Given this list of marker genes Cox6a1, Mt2, Snx21 (sorting nexin family member 21), Gfra2, Fabp5, Ngfr, Tgfbi, Slc25a4, Cltb, Hnrnpab, Havcr2, Sult1a1, Ddr1, Tmem256, Cd244a, Runx1, Casp6, Snap23, Ms4a6d, Socs3, Rnh1, Gpatch11, Tspo, Ugcg, Gcnt1, Ifitm2 (NCBI Gene Id 80876), Olfm1, Adpgk, Mrpl52, Edem1, Cyp4f16, Fcgrt, Dhx9, Slc39a1, Flot1, Gpr146, Cyrib, Ndufv2, Cdk2ap2, Wfdc17, Ap1s2, Snrpa, Lyn, Skap2, Ocstamp, Fkbp5, Mt1, Smdt1, Gpr183, Pirb (NCBI Gene Id 18733), Gapdh, Clec4n, Pmvk, Septin3, Cpne2, Gpr171, Kif1a, Rab3il1, Wdr1, Gcnt2, Cox7a2, Dpysl2, Apod, Bcl2l14, Hip1, Tuba1b, Slfn2, Cux1, Pik3ip1, Klf13, Gatm, Srgn, Spint1, Xbp1, Scarb1, Scimp, Slc44a2, Vdac3, Jak2, Ubqln1, Tle3 (transducin-like enhancer of split 3), Fyn (Fyn proto-oncogene), Ikzf1, Runx3, Tspan13, Gpr35, Id2, Caap1, Sla, Zdhhc23, Myd88, Ptpn1 (protein tyrosine phosphatase, non-receptor type 1), Cdkn2d (NCBI Gene Id 12581), Spi1, Fgr, Ece1, Arf1, Ifitm1, Ap2a2, Nr4a3, Ddit4, Snx1, Timm10b, Bcl11a, Naga (NCBI Gene Id 17939), Bcl3, Cd53, Naaa, Exosc3, Efhd2, Hsp90b1, here is a description of the gene set: species: Mus musculus Genes positively differentially expressed in cell type: cDC2 (conventional dendritic cell type 2) upon treatment with cytokine: OSM in mouse lymph nodes in vivo. from publication Cui A, Huang T, Li S, Ma A, Pérez JL, Sander C, Keskin DB, Wu CJ, Fraenkel E, Hacohen N (PMID 38057668) Cytokines mediate cell-cell communication in the immune system and represent important therapeutic targets. A myriad of studies have highlighted their central role in immune function, yet we lack a global view of the cellular responses of each immune cell type to each cytokine. To address this gap, the authors created the Immune Dictionary, a compendium of single-cell transcriptomic profiles of more than 17 immune cell types in response to each of 86 cytokines (>1,400 cytokine-cell type combinations) in mouse lymph nodes in vivo. A cytokine-centric view of the dictionary revealed that most cytokines induce highly cell-type-specific responses. For example, the inflammatory cytokine interleukin-1β induces distinct gene programmes in almost every cell type. A cell-type-centric view of the dictionary identified more than 66 cytokine-driven cellular polarization states across immune cell types, including previously uncharacterized states such as an interleukin-18-induced polyfunctional natural killer cell state. Mouse Gene Set: CUI_CDC2_OSM_RESPONSE_UP